Given this list of marker genes RANBP2, FCGR2C, LRP5, ARPC1B, ERCC6, GNAQ, CTNNB1, COL4A1, SMC5, GCDH, ZNF408, HMCN1 (NCBI Gene Id 83872), CYSLTR2, FZD4, DNM2, LAMB2, CFH (complement factor H), APOE, ESAM, ABCC6, XYLT2, IKBKG, BAP1, TERC, SBDS, ATP6V0A2 (NCBI Gene Id 7854), DST, TREX1, SF3B1, CFI, ENPP1, ATP6V1A, GNA11, ERCC8, CAPN5, ZEB2, TERT, NDP (NCBI Gene Id 4693), TSPAN12 (NCBI Gene Id 23554), BEST1, IFNG, CFHR1, RS1, RB1, CFHR3, ATP6V1E1, ATOH7, EFEMP1, PRF1, PROC, MYD88, XYLT1, HBB, here is a description of the gene set: studied in species Homo sapiens Hemorrhage of the eye Bleeding from vessels of the various tissues of the eye. Human Gene Set: HP_HEMORRHAGE_OF_THE_EYE